The following is a description of a gene set: Human Gene Set: GOMF_KINASE_BINDING Binding to a kinase, any enzyme that catalyzes the transfer of a phosphate group. species: Homo sapiens, and this is the list of marker genes: PITPNM1, SIKE1, KIF14 (kinesin family member 14), RAB8A, PINK1, RHOD (NCBI Gene Id 29984), IL12RB2, RGS14, MAVS, CIR1, NRG3, CASP9, SPDYE17, CEACAM20, FBXO7, PHYHIP, APP, BCL2L1, TRAP1, MAPK7, PARN, GATA4, CCNT2, PPP2R5A, CDKN2B, ROR2, CDK12, TRADD, ACTG1, RHOBTB2, MYOM2, SPG11, AURKA, DLG2, DGKH, WWC1, CD6, AXIN1, CEACAM7, STK38, MAPK8IP1, CNKSR2, PITPNM2, MAP2K3, FLT3LG (NCBI Gene Id 2323), DAB2IP, CLTC, SPRED1 (sprouty related EVH1 domain containing 1, NCBI Gene Id 161742), MSN, CDKN2C, HSPB1, MAPK8IP3, KCNQ1, TNIP2, SMO, PPP1R9B (protein phosphatase 1 regulatory subunit 9B), KAT2B, EIF4ENIF1, AXIN2, DAZAP2, DGKQ, CCNB1, PER1, POTEI, NELL1, SH2B3, SPDYE15, GAB4, DOK2, LRRC7, DVL2, SCN5A, DSCAM, SPDYE21, CRY2, SP100, SPDYE8, AKT1, EGFR, CBLB, RYR2, MICAL1, SREBF1, MAPK6, PLCG2, RASGRP3, CLASP2, CRKL, WDR45, GRB2, CEP152, RHOV, MAP2K6, STK11IP, ZBTB4, ACTB, CASS4, IRAK4, RND2, NBR1, AP2A1, RNF13, IRAK3, DSP (desmoplakin), CEBPA, ERCC6L2, CD24, ATF4, CDK5RAP1, RPTOR, SOCS1, CSPG4, DLG3, ABL1, ELMO2, UFL1, SPRY2, GCSAM, PRR7, ITGB2, UGT1A10, SH2B1, ILK, IRF5, CDK5RAP3 (NCBI Gene Id 92989), CDH2, PRLR, TNS2, MAP2K7, SHC1, INKA2, WWC3, SOX9, TFRC, YWHAZ, STX1A, STRADA, SUFU, BCL10, ADCY4, ACE, CDC25B, SHC3, CHIA, APC, KIF11, SPDYE3, PTPN23, GFRAL, PLEK, BAG5, MAPRE3, CAMK2N1, RPS6KA3, ZPR1, CEP68, SGO1 (NCBI Gene Id 151648), XBP1, MAPK8IP2, CAB39, TTN, RPS19, RAB11FIP2, FGR, CCNE2, TRIM72, ABI2, EEF1A1, PRKG1, MYOC, PPME1, SOS1, PPP1R12B, SIRT1, TRIB2, CDK5R2, RARA, NAIP, PRKAR1B, GPX1, FAM83H, PPP1CB, MAP3K1 (NCBI Gene Id 4214), ACVRL1, DACT2, TOB1, CHEK2, TAOK2, ADCY6, HSP90B2P, ACTA2, SPAG9, FZD5, EEF1A2, SPDYC, GAS6, ITGB3, VHL, FAM83F, BTG1, MYH6, PJA2, PRKAR2B, ADAM9, PRMT1, TAX1BP1, IBTK (inhibitor of Bruton tyrosine kinase), SOCS5, ANGPT1, PARP8, TRIP6, SIT1, DOCK4 (dedicator of cytokinesis 4), CDKN1A, ANGPT2, TPRKB, TPCN2, ALKAL1, CCDC88A, PPP1R12A, LRP4, PAK2, CKS1B, FBXW5, RGCC, ATG13 (autophagy related 13), PLK1, CDC6, SPDYE12 (speedy/RINGO cell cycle regulator family member E12), DAXX, PIH1D1, SRSF5, TRIP4, USP37, CHP1, JAKMIP1, KCNA5, MAPKAPK3, MAPKAPK2, GSK3B, E2F1, IFNAR2, PIWIL1, CARD16, HDAC5, RND3, MAPKAPK5, PDE8A, FRMD5 (NCBI Gene Id 84978), UGT1A7, PRKCH, ITGB1BP1, BLNK (NCBI Gene Id 29760), STING1, HTT, SMAD3, BECN1, ARHGAP33, TRIM6, PRKAR1A, CD2, PTPN2, KSR2, RPS7, TBL2, STX17, NCK2, ATF2, CAVIN3, GATA6, ZFYVE26, IL31RA, DUSP22, SPRED3, NOD2, TRAF2, RB1CC1, DOK7, CKS2, DNAJB2, ANGPT4, CCDC102B, HYAL2, APPL1, CCND1, EPHA4, DACT1, DCX, PRKCSH (PRKCSH beta subunit of glucosidase II), PCNA, CACUL1, SIK1, IRS2, CEACAM1, TTC28, NOX4, TRIM5, RHOH, GIT1, PRKAG3, BORA, MVP, SLC12A5, TELO2, GOLGA2, SYN1, MICAL2, CBL, TRAF4, FERMT2, DCTN1, LAX1 (lymphocyte transmembrane adaptor 1), NTRK1, TJP2, GRM5 (glutamate metabotropic receptor 5), SPDYE5, AGAP2 (ArfGAP with GTPase domain, ankyrin repeat and PH domain 2), GP6, ATP2B4, RFFL (ring finger and FYVE like domain containing E3 ubiquitin protein ligase), SLC2A1, PPP1CC, PTN, PRKG2, PTPN5, BICD1, ZC3HC1, MARCKS, GFAP (NCBI Gene Id 2670), LAT, CEACAM4, CCNYL1, TNIP1, PTPN14, NR3C1, DGKD, SMAD1, ANKRD2, RELB, PDGFRB, FAM83E, RAC1, BAD, SPRED2 (sprouty related EVH1 domain containing 2), CDK13, KHDRBS1, HSP90AA1, SPDYE16, ATF7, CDC37, CASP1, FRS3, FAM83D, RGS4, POTEF, FBXO5, CALM3, ALKAL2, STUB1, CTNNB1, MAP3K13, PIN1, JAKMIP2, PICK1, WNK1, SYK, MOB1B, TICAM1, CDC42, RELA, LDB3, NCK1, UTRN, ADAM10, ANK2, CRK, SRCIN1, CPNE3, PRDX3, TOLLIP, ARTN, MAPRE2, TBC1D14, BCAR1, TWF2, GRIA1, MAML1, DNAJC3, CBLC, PARK7, FCRL3, DUSP3, ARHGEF7, LRBA, TSKS, MAG, SQSTM1, FAF1, MAP2K1, JAKMIP3, TP53, C1QBP, STAU2, CALM2 (NCBI Gene Id 805), SMIM26, ITGAX, DCTN2, UBQLN1, UNC5C, PFKM, PLG, TDG, PKN1, TAB1, PDLIM5, TPR, MST1, PPARA, PRKD1, RHEB, FNTA, CDH5, EZR, BARD1, CEACAM3, ERRFI1, SHC4, LCK, GRK5, PRKCD, BRSK1, RNF138, PPP5C, PRAM1, TIRAP, CDC25C (NCBI Gene Id 995), LIMS1, CCNY, AVPR1B (NCBI Gene Id 553), CYLD, PRKACA (protein kinase cAMP-activated catalytic subunit alpha), RAD9A, PGAM1, BCL2L14, CDK5R1, GPRC5B, ARHGEF16, WAS, TUBA4A, GSTP1, MTCP1, ELP2, TEX14, VRK2, DVL1, NELL2, ACP4, ITGB1, PYDC1, FRS2, ADRA2A, SPDYE2B, RNF41, PKIA (cAMP-dependent protein kinase inhibitor alpha), ATG101, SLC12A7, ARRB2, MAP3K2, NPM1, PARP16, MAP3K7, FIRRM, TOM1L1, GLRX3, TNFAIP3, MAPK4, GSN, RHOA, MAPK8, SLC12A2, HSF1, MYCN, EXOC2, PPP1R12C (protein phosphatase 1 regulatory subunit 12C), STRIP1, INKA1, SIRPA, XIAP, PTPRR, SPDYE10, LIME1 (Lck interacting transmembrane adaptor 1), LLGL1, PKP2, SFN, PER3, POLA1, SASH1, POTEKP (POTE ankyrin domain family member K, pseudogene), SKAP1 (src kinase associated phosphoprotein 1), MAPK14, PFKL, CALM1, RBBP6, SNAI1, PPEF2, PRKAR2A, CSK, CDKN2A, DNM1, NSF, MAPRE1, PEBP1, LRRC14, STAP1, MAPT, LATS1, VDAC1, QARS1, EIF3A, CAV2, BMPR2, RAD23A, FAM83C, CD4, TRAF3, SV2A, IL15RA, SPDYE1, SPDYE2, SHC2, CDH1, PLCG1, BCAR3, PRC1 (protein regulator of cytokinesis 1), MST1L, STAT3, HDAC7, GRB14, CEBPB, CIT, SPDYE18, ADIPOR1, RHOC, NEK9, SPDYA, NBEAL1, NR4A3, TBR1, HNRNPA0, PAK1, TCF7L2 (transcription factor 7 like 2), GDF3, ACTL8, CCNE1, FEZ1 (fasciculation and elongation protein zeta 1), HES1, ZFP36, PIP5K1A, ACVR1, EEF2, TIAM1, SRSF1, HIF1A, TNNI3, NEDD9, CDKN1B, ATF5, RCC2, ADD3, NRTN, SDC4, AP1B1, MAP3K12, FOXO3, HCLS1, MIDN, FLNA, CD28, SPDYE6, HPCA, ACSL3, RHOQ, ELAVL1, PSPN, PITPNM3, NBEA, CADM4, TCL1B, ESR1, PTPN22 (protein tyrosine phosphatase non-receptor type 22), WWC2, TRIB3, LAPTM4B, USF1, DUSP16, GDNF, RPS6, TRAF6, IQGAP1, KIZ, EMP2, MT-ND2, TREM2, RHOU, DUSP12, GNAT1, CD226, MAPKAP1, CNPPD1 (cyclin Pas1/PHO80 domain containing 1), PTK2, PRKAB1, ATP1B1, PPP1R15A, TOM1L2, SNAP91, PRKD2, SPDYE7P, FAM83B, NEFH, CADPS, WARS1, MYOM1, IRAK1, IKBKB, TRPV4, CRY1, MARVELD3, TRIM22, FIZ1, DLG1 (NCBI Gene Id 1739), POLR2A, ANKRA2, PRKRIP1, SPDYE14 (speedy/RINGO cell cycle regulator family member E14), ATP1A4, MAP3K11, TPX2, ITGAV, PAX6, SLC12A4, CCNK, SH2B2, KIF13B, CD247, FOXM1, HSPB6, DUSP2, RHOG, DUSP19, RHOJ, CIMAP3, FAM83G, CASR, CDKN2D, DLG4, TCL1A, BANK1, PFKFB2, NBEAL2, GHR, RAC3, CCNYL2, KIF20A, NFATC1, DBF4B, OXSR1, FAM83A, PTPRJ, RHOBTB1, SCRIB, PTPN11, CAV1, RACK1, RB1, TRAT1, CDK5RAP2, RPS3, PDCD10, CD160, PRKAB2, TOP2A, CCND3, BRSK2, CAMK2N2, PDE3B, GADD45A, ACTBL2, SPDYE4, CENPJ, FAS, BCL2L11, RICTOR, AP2A2, CAVIN2 (caveolae associated protein 2), PIK3R1, CEP43, NRP1, PKD1, GRB7, HSP90AB1, PIK3R2, MAP4K2, RHOF, PARP6, DUSP10, HINT1, DIRAS1, PTPN6, PPM1D, POTEE, CCND2, PRKN, PRKAG2, YWHAG, STXBP1, PTPRK, SKI, IRS1, BACE1, DNAJA3, TCF3, CACNB4, WDCP, MAD2L2, CNTLN, DELE1, BCL11A, GCH1, ADD2, GAB2, LDHB, PTPN1 (NCBI Gene Id 5770), AVPR1A (arginine vasopressin receptor 1A), GSKIP, STX1B, RACGAP1, GSK3A, MEF2A, SMCR8, PRKCB, NEK6, JAK2, SPDYE11, PRKAG1, PARP1, DUSP1, AURKB, TRIM49, IRGM, MAP3K5, TP73, MCRS1, GRAPL, AKAP7, POTEJ, SLC12A6, MLKL, TRIB1, CD3E (CD3 epsilon subunit of T-cell receptor complex), PTPRC, STK39, ERBB2, DACT3, VRK1, CCNT1, CDC25A, TESK1, RND1, JTB, NRG1, CCNA2, CTBP2, MACROH2A1, HDAC9, CDK9, EPHA1, RAC2 (NCBI Gene Id 5880), CNOT9